Given this list of marker genes NR4A1, PIP, NCOA7, CD55, CLDN4, SCGB1A1, CD24, STATH, PIGR, IVNS1ABP, VMP1, C6orf58, CXCL8, MAFF, ZG16B, CXCL1, PRB3, LYZ, BPIFA1, KRT7, CXCL3, LTF, CYP4B1 (NCBI Gene Id 1580), BPIFB1, CXCL2, ANXA1, FDCSP, ODAM, DMBT1, here is a description of the gene set: studied in species Homo sapiens Human Gene Set: DURANTE_ADULT_OLFACTORY_NEUROEPITHELIUM_RESPIRATORY_SECRETORY_CELLS from publication Durante MA, Kurtenbach S, Sargi ZB, Harbour JW, Choi R, Kurtenbach S, Goss GM, Matsunami H, Goldstein BJ (PMID 32066986)